Given this list of marker genes PUS3, PUS1, TRUB2, TRUB1, PUSL1, PUS10, RPUSD4, PUS7, here is a description of the gene set: Human Gene Set: GOMF_TRNA_PSEUDOURIDINE_SYNTHASE_ACTIVITY species: Homo sapiens Catalysis of the reaction: tRNA uridine = tRNA pseudouridine. Conversion of uridine in a tRNA molecule to pseudouridine by rotation of the C1'-N-1 glycosidic bond of uridine in RNA to a C1'-C5.